The following is a description of a gene set: from publication Bauer AK, Rondini EA, Hummel KA, Degraff LM, Walker C, Jedlicka AE, Kleeberger SR (PMID 21543283) We previously identified toll-like receptor 4 (Tlr4) as a candidate gene responsible for ozone (O3)-induced pulmonary hyperpermeability and inflammation. The objective of this study was to determine the mechanism through which TLR4 modulates O3-induced pulmonary responses and to utilize transcriptomics to determine TLR4 effector molecules. C3H/HeJ (HeJ; Tlr4 mutant) and C3H/HeOuJ (OuJ; Tlr4 normal), mice were exposed continuously to 0.3 ppm O3 or filtered air for 6, 24, 48 or 72 hr. Affymetrix Mouse430A_MOE gene arrays were used to analyze lung homogenates from HeJ and OuJ mice followed using a bioinformatic analysis. Inflammation was assessed by bronchoalveolar lavage and molecular analysis by ELISA, immunoblotting, and transcription factor activity. TLR4 signals through both the MYD88-dependent and independent pathways in OuJ mice, which involves MAP kinase activation, NF-kappaB, AP-1, and KC. Microarray analyses identifiedTLR4 responsive genes for strain and time in OuJ versus HeJ mice (p<0.05). One significantly upregulated cluster of genes in OuJ were the heat shock proteins (Hspa1b; Hsp70), Hsp90ab1). Furthermore, O3-induced expression of HSP70 protein was increased in OuJ compared to HeJ mice following 24-48 h O3. Moreover, BAL polymorphonuclear leukocytes (PMN) and total protein were significantly reduced in response to O3 in Hspa1a/Hspa1btm1Dix (Hsp70-/-) compared to Hsp70+/+ mice (p<0.05). TLR4 signaling (MYD88-dependent), ERK1/2, AP-1 activity, and KC protein content were also significantly reduced after O3 exposure in Hsp70-/- compared to Hsp70+/+ mice (p<0.05). These studies suggest that HSP70 is involved in the regulation of O3-induced lung inflammation through the TLR4 pathway and provide evidence that HSP70 is an endogenous in vivo TLR4 ligand. Human Gene Set: GSE20715_0H_VS_24H_OZONE_TLR4_KO_LUNG_DN Genes down-regulated in comparison of lung tissue from wild type mice subjected to ozone for 0 h versus that from TLR4 deficient mice subjected to ozone for 24 h. studied in species Homo sapiens, and this is the list of marker genes: VAPA, POLR1C, LPL, TMCC3, MYC, CAPN2, PTPN11, MYOM1, RIOK2, IDH3A, RANBP9, SFN, ATP6V1G1, FBXO15, KCNK1, KRT18, ITPRID2, BCL2L1, ZBTB16, FASN, IFRD1, DNAAF5 (dynein axonemal assembly factor 5), NFIL3, UBE2G2, AMOTL2 (NCBI Gene Id 51421), PHF10, BCL3, CDKN1A, OXSR1, HSD11B1, TRIM29, PDK4, DCTN3, CCDC71L, SH2D3C, EIF4E (eukaryotic translation initiation factor 4E), USP8, HSPA5, RAMP2, NEDD4L, BMP2, FST, CXCL17, ACTC1, MT1E, MYD88, ACER2, CKMT2, RRAS2, IL1RAP, PLA2G12A, GDPD1, MT2A, BMAL1, THBS1, GJB6, F3, TIMP1, ESRP2, LPAR1, SLC10A6, SEMA7A, LYVE1, KPNA1, SLC23A2, RHOU, SELENBP1, RAP1A, PLIN2, FER, ADAMTS15, PRDX6, ETF1 (NCBI Gene Id 9190), EDN1, SLC7A6, ATF4 (activating transcription factor 4), KCMF1, GLUL, CTSH, MAL, NEK7, DAPK1 (death associated protein kinase 1), PKP4, LAMA2, SLC3A2, ANGPT1, PRKAR2A, LGALS3, ORC4, ECHS1, LBP, CCN2, GSPT1, HGF, IFNGR1, CARHSP1, MYOM2, RGS4, ALKBH5, ALDH3A1, CTTNBP2NL, RSRP1, ITGB1BP1, SPP1, PPRC1 (PPARG related coactivator 1), DUSP6, COP1, STK39, KPNA2, LTBP2, VMP1, TGM1, MTA1, MAN2A1, SLC15A2, ANLN, NDE1, SLC45A3, ELN, PGD, HEXIM1, EIF3J, MAFF, LIPE, TLR4, ADORA2B, ACTN1, EPHA2, SERPINA3, CDO1, CSNK1E, HINT1, SLC39A14, LDLR (low density lipoprotein receptor), ZFPM1, HP, AP3S1, ELF3, MFAP2, PMEPA1, OSMR, MAPK1, RPRD1A, CCL17, ANAPC16, GPX2, MMP14, LGALSL, ORC2, FAM216A, STAU1, CDK18, TRIM3, KCNE2, SLC30A7, PRR14, C6orf136, CCDC85A, ARHGEF7, SEMA5A, ADM (NCBI Gene Id 133), SENP2, SPSB1, PDE4DIP, HILPDA, ANGPTL4, MYBPC3, LRG1, CCL22 (C-C motif chemokine ligand 22), SNRK, SAA1 (NCBI Gene Id 6288), HSD17B4, ARG2, SOCS3, CFB, HOMER2, LRRC2, PLEKHF2, EIF6, TUBB6, ABHD17C, ZFAND2A, ARL4D (ADP ribosylation factor like GTPase 4D), DYRK1A, ERLIN1, KCTD10, MLXIP, PPA1, AREG, GSTA3, MAN1A2 (mannosidase alpha class 1A member 2), GADD45G (growth arrest and DNA damage inducible gamma), GOT1, NPR3, CXCL2, LCN2, LRRC59, COL4A1, LOX, LEPR